Given this list of marker genes CARM1, PRMT6, PRMT2, PRMT3, PRMT8, PRMT1, METTL23, here is a description of the gene set: Human Gene Set: GOMF_PROTEIN_ARGININE_OMEGA_N_ASYMMETRIC_METHYLTRANSFERASE_ACTIVITY Catalysis of the addition of a second methyl group to methylated peptidyl-arginine. Methylation is on the same terminal nitrogen (omega nitrogen) residue that was previously methylated, resulting in asymmetrical peptidyl-N(omega),N(omega)-dimethylated arginine residues. species: Homo sapiens